The following is a description of a gene set: from publication Feuerer M, Hill JA, Kretschmer K, von Boehmer H, Mathis D, Benoist C (PMID 20231436) Human Gene Set: GSE20366_CD103_POS_VS_NEG_TREG_KLRG1NEG_DN Regulatory T (Treg) cells that express the FoxP3 transcription factor are essential for lymphoid homeostasis and immune tolerance to self. Other non-immunological functions of Treg cells, such as controlling metabolic function in adipose tissue, are also emerging. Treg cells originate primarily in the thymus, but can also be elicited from conventional T cells by in vivo exposure to low-dose antigen or homeostatic expansion, or by activation in the presence of TGFβ in vitro. Treg cells are characterized by a distinct transcriptional signature controlled in part, but not solely, by FoxP3. For a better perspective on transcriptional control in Treg cells, we compared gene expression profiles of a broad panel of Treg cells from various origins or anatomical locations. Treg cells generated by different means form different sub-phenotypes identifiable by particular combinations of transcripts, none of which fully encompass the entire Treg signature. Molecules involved in Treg effector function, chemokine receptors, and the transcription factors that control them are differentially represented in these subphenotypes. Treg cells from the gut proved dissimilar to cells elicited by exposure to TGFβ, but instead they resembled a CD103+Klrg1+ subphenotype preferentially generated in response to lymphopenia. Genes down-regulated in comparison of TregCD103-Klrg1- versus TregCD103+Klrg1- (see Table 1S in the paper for details). studied in species Homo sapiens, and this is the list of marker genes: MLANA, EDEM1, PER3, PRKAR2B, EHD4, GCFC2, TSPOAP1 (TSPO associated protein 1), GABPB1, FAM133B, VPS41, SPRY1, ANKRD6, KLF12, S100A4, PLEKHA8, EVI5, TRMT2B, ENTPD1, RHBDD1, ASB17, GZMB, TTN, CEP290, PTPN22, MTMR11, FRMD4B, NIPA2, ATP10B, PLEKHA2, TRAM1, GAA, POU4F1, ENPP1, IL17RB, VWA5A, CPXM2, CHIC1, F2R, NDNF, HLTF, GBP4, UBTFL1, PWP1, DHX33, SLC25A53, ALCAM, OR8A1, HIF1AN, ANKRD54, KIF13B, STK32A, FBXO30, METAP1, CHRNA1, CCR4 (NCBI Gene Id 1233), S100A5, PRDM14, DMD, PNPLA8, PRICKLE1, FGD6, NAV2, HSPA12B, ZNF572, REXO5, BCHE (NCBI Gene Id 590), PPP2R2A, AP3M1, MYO1F, CASS4, HADH, EPHX3, TMEM175, ADAMTS5, ZCCHC18, ATP6V0D2, WDR90, ACVR2A, TMEM130, SLITRK6, PIH1D2, FNDC3B, DCUN1D4, UBASH3B, EFCAB14, PPP2R1B, ZDHHC2, MAN1C1, AKAP10, KIF5C, PPP4R2, KANK3, PBX3, GALM, GCH1, SEC11C, NUDCD2, PLAGL1, MANBA, BMP2, AHRR, EIF3A, ACOT9, MYL7 (NCBI Gene Id 58498), STXBP6, BMAL1 (NCBI Gene Id 406), RNF4, CHD9, BDNF, ANG, C9orf72, EHD1, FRMD5, BST1, FRZB, ADCYAP1, SLC39A6, DKKL1, MRGPRE (MAS related GPR family member E), PSTPIP2, ZNF142, ARMCX4, CHMP4B, RNF19B, ITGA3, CYBB, CHTOP (chromatin target of PRMT1), SPCS3, CYP2S1, LTBP3, OSBPL3, ICOS, WDR7, WNK1, FGL2, MAGEH1, IL15RA, NRARP, TGFBR1, ZPBP2, P2RY10, TMIGD1, CLIP1, NTF4, PCDHGC4, DYNLT3, MDFIC, BAIAP3, KY, LAMP2, TFAP2C, NCKAP1, GALNT13, NIPA1, ARRDC4, HPSE, TIMP2, PPP1R27, RBL2, MED7, ACRV1, MSH6, CD70, DCLK2, SLC35F5, SLC39A4, ITPRIPL2, KCNK3, MYO3B, CCDC117, ANKRD29, SNX25, MAGED1, HUS1, PEAR1, RNF157, CEP112, DIPK2A, CSF1, FHIP1B, FOSL2, CXCR3, GCNT1, DSP, N4BP1, FARP1, CCR5, NUCB2, IFT81, IL1RL1, IFNG, MDGA2, GLIS2, PPIL4, PTPRJ, MBD2, AXL, TMEM30B, NUDT4, RNF115